Given this list of marker genes GBF1, RARB, ZNF582-DT, ENTPD7, FLCN, GAB1, EPHA5, MIR1915HG, UXS1, COLGALT2, KCNA4, CADM1, EFNA5, KLF11, LINC01305 (long intergenic non-protein coding RNA 1305), NKX2-3, VSTM2A, CPVL, TMED5, WNT5A, PLA2G15, IRX1, ARRDC2, VPS8, ZNF582, SETBP1, LINC01012, ADGRL3, C6orf118, MCTS1, SSTR2, COMMD9, OSR1, SMCHD1, PUS10, TRHDE, RSPH4A, TTBK1, MMP16, VPS37B, HOXA7, FBXO4, RUNDC3B, RRP15, TAC1, ZNF180, CFP, MTERF1, ZNF304, SLC25A29 (solute carrier family 25 member 29), MARK2, LCOR, EPHA5-AS1, HAND1, SBSPON, CDH26, HOXA1 (homeobox A1), SLC7A8, HOXB13, SUSD5, GDNF, PCDHGB6, NIPAL3, CTXN2, DNAJB5, LINC01230, here is a description of the gene set: studied in species Homo sapiens from publication Nouzova M, Holtan N, Oshiro MM, Isett RB, Munoz-Rodriguez JL, List AF, Narro ML, Miller SJ, Merchant NC, Futscher BW (PMID 15302897) Human Gene Set: NOUZOVA_METHYLATED_IN_APL Dysregulation of epigenetic control is an important participant in carcinogenesis. The PML/RAR alpha translocation in acute promyelocytic leukemia (APL) is an example where the resultant fusion protein recruits histone deacetylase complexes to target genes resulting in their inappropriate transcriptional repression. All-trans-retinoic acid (ATRA) acts as a ligand that relieves this repression and produces an epigenetic transcriptional reprogramming of the cancer cell. CpG island microarrays were used to analyze the DNA methylation and histone acetylation state of the human APL cell line NB4 before and after differentiation with ATRA as well as normal peripheral blood mononuclear cells (PBMC). Over 70 CpG islands within 1 kb of transcription start of a known gene are aberrantly methylated in NB4 cells compared with PBMC; however, no changes in cytosine methylation were detected following ATRA-induced differentiation. With respect to histone H4 acetylation, over 100 single-copy CpG islands within 1 kb of transcription start of a known human gene became hyperacetylated following ATRA-induced differentiation. One CpG island was aberrantly methylated in NB4 cells, but became hyperacetylated and was induced following ATRA treatment and was associated with the HoxA1 gene, suggesting it may be a target gene of ATRA in APL. In addition to single-copy sequences, a selective increase in acetylation was detected in satellite DNA when compared with other high-copy sequences, such as Alu or rDNA. In summary, ATRA stimulates complex epigenomic changes during leukemic cell differentiation, and monitoring these changes may help to identify new targets of epigenetic dysfunction. Genes whose CpG islands are hyper-methylated in the NB4 cell line (APL, acute promyelocytic leukemia) compared to PBMC (normal peripheral peripheral blood mononuclear cells).